Given this list of marker genes Pycr1, Mef2c, Axl, Chl1, Cntf, Lgmn, Cdk5, Tfap2a, Nox1, Gata3, Grik2, Mir7116, Fzd1, Casp2, Crlf1, Mybl2, Ccl3, Gpi1, Clu (NCBI Gene Id 28201), Akt2, Hipk2, Mdk, Bdnf, Xiap, Phb1, Lrp1, Nr4a3, Pla2g3, Casp4, Foxb1, Ager, Nfix, Foxq1, Mt3, Nes, Itga1, Fgf2, Fzd9, Agap2, Il1b, Casp6, Pin1rt1, Oxr1, Ccr5, Fam162a, Casp3, Rapsn, Nae1, Pou4f1, Btg2, Ntf3, Kdm2b, Ndnf, Ppargc1a, Atp7a, Minar2, Ambra1, Mir124a-1, Esr2, Nono, Isl1, Pou4f3, Agt, Epha7, Mt1, Slc1a1, Pik3ca, Vps54, Mtor, Bcl2, Siah1b, Pcdhgc4, Tnf, Slc25a27, Crh, Atm, Tgfb2, Col6a2, Parp2, Agtr1a, Ncf2, Htra2, Fcgr2b, Prkci, Siah1a, Cln8, Bok, Thap11, Vegfb, Jak2, Optn, Apaf1, Hmox1, Bace1, Cntfr, Bnip3, Apoe, Lcn2, Akt1s1, Adnp, Fbxw7, Map3k5, Scn2a, Amigo2, Gapdhrt2, Cpeb4, Sigmar1, Dnajc5, Tmbim6, Hyou1, Ctsb, Col6a3 (NCBI Gene Id 98389), Ube2v2, Sncb, Kcnb1 (NCBI Gene Id 16500), Enpp1, Ube2m, Faim2, Fasl, Dlx1, Kcnq2, Aimp2, Fgf8, Col6a1, Myb, Fas, Pcdhgc5, Mfsd8, Ascl1, Ntrk1, Egln1, Tnfrsf21, Nfatc4, Stambp (STAM binding protein), Trp73, Thrb, Agtr1b, Trem2, Ucn, Mdga2, Cdc42, Kdr, Lig4, Spg11, Gpx1, Glp1r, Barhl1, Tfap2d, Sirt1, Ptpn5 (protein tyrosine phosphatase, non-receptor type 5), Cx3cr1, Ncstn, Ppp2r2b, Wnt1, Gsk3b, Pcdhgc3, Fadd (Fas associated via death domain), Grn, Xrcc2, Six1, Ubb, Ptprf, Jun, Gapdhrt, Grik5, Rnu12, Fgf20, Tfap2b, Fbxo7, Casp14, Musk, Bbc3, Grm7, Six4, Nlrp1a, Cdc34, Usp53, Aars1, Adcy10, Star, Crhr1, Ucp2, Grin1, Clcf1, Gdnf, Pdpk1, Fxn, Il27ra, Kcnq3, Sarm1, Diablo, Mir124a-2, Rock1, Hsph1, Angpt1, Egr1, Adora2a, Prkn, Atf2, Hdac4, Adarb1, Gdf5, Ctnnb1, Map3k11, Casp12, Gba1, Trp53, Sema3e, Bbs10, Cdc34b, Epg5, Set, Tgfb3, Ndp, Cx3cl1, Stxbp1, Nefl, Parp1, Cebpb, Gclc, Egln3, Casp8, Ppt1, Nsmf, Wfs1, En1, Syngap1, Elp6, Draxin, Map2k7, F2r (NCBI Gene Id 218465), Polb, Cdk5r1, Pcsk9, Fgfr3, Epor, Max, Tgfb1, Bcl2l1, Il18, Grid2, Snx6, Mcl1, Nppc, Prkcg, Adam8, Mapk8, Msh2, Cflar, Sod2, Xrcc4, Sod1, Rhoa, Cacna1a, Agtr2, Kcnma1 (potassium large conductance calcium-activated channel, subfamily M, alpha member 1), G6pdx, Ripk1, Trp63, Ngf, Ccnd1, Trim2, Tnfrsf1a, Abl1, Atg7, Bax, App, Npm1, Psen1, Ptges3, Kif14, Trpc5, Retreg1 (NCBI Gene Id 66270), Arrb2, Unc5b, Fis1, Hsp90ab1, Nlrp1b, Tmtc4, Tmbim4, Esr1, Mag, Epha4, Kras, Birc5, Traf7, Aifm1 (apoptosis-inducing factor, mitochondrion-associated 1), Snca, Mtnr1b, Hdgf, Nos1, Park7, Map3k12, Elk1, Agrn, Cited1, Il6, Rad21, Vegfa, Rb1, Gclm, Prodh (proline dehydrogenase), Arrb1, Plxnd1, Hdac3 (NCBI Gene Id 15183), Prdx2, Nf1, Pak3, Ptk2b, Prdx3, Alkbh1, Pmaip1, Itsn1, Fmr1, Fyn, Zpr1, Pink1, Tox3, Ntrk2, Sct, Il6st, Ddit3, Pcp4, Pin1, Atn1 (atrophin 1), C5ar1, Hras, Gch1 (NCBI Gene Id 14528), Tert (telomerase reverse transcriptase), Cd2ap, Ilk, Gapdh, Foxo3, Grina, Bag1, Ngfr, Srpk2, Hrk, En2, Nrp1, Nqo2, Gbe1, Zfp110, Nr3c1, Cblc (Casitas B-lineage lymphoma c), Prnp, Mecp2, Braf, Ndufs4, Egln2, Gsk3a, Il10 (interleukin 10), Nrbp2, Casp7, Grk1, Arsg, Nupr1, Daxx, Tuba1a, Cit, St8sia2, Pitx3, Vstm2l, Map2k4, Bcl2l11, Atf4, Erbb3, Htr2a, Gfral, Nqo1, Tyro3, G6pd2, Bhlhb9, Htt, Nmnat1, Npr2, Aatk, Lonrf2, Mmp2, Hspa4, Ntf5, Zfp212, Smo, Pigt, Dio3, Gmppa, Ccl12, Pawr, Coro1a, Kcnip3, Hspd1, Hif1a, Cln3, Nr4a2, Tmbim1, Ptprz1, Casp9, here is a description of the gene set: species: Mus musculus Mouse Gene Set: GOBP_NEURON_APOPTOTIC_PROCESS Any apoptotic process in a neuron, the basic cellular unit of nervous tissue. Each neuron consists of a body, an axon, and dendrites. Their purpose is to receive, conduct, and transmit impulses in the nervous system.